Given this list of marker genes NUDT4, GSPT1, DSCC1, MPO, CEP76, TPM1 (NCBI Gene Id 7168), PALM2AKAP2, ITGB3BP, CCNB1, NUP85, NT5DC2, NUSAP1, MS4A3, RNASEH2A, CENPA, MRPS15, SPAG5, DLGAP5, CCNE1, MICAL2, DHFR, SUB1, CPA3, ARHGAP19, RAB31, RACGAP1, CSE1L, KIF2C, TUBB6, DLC1, PF4, PRDX4, BRCA1, ACTN1, CCNA2, ABCC4, KLHL7 (kelch like family member 7), CPOX, HBD, VRK1, HSPA14, CHEK1, FEN1, MCM10, AQP3, CCNE2, MCM4, IDH2, UBE2C, KIF18B, PROS1, TK1, TOP2A, RRM2, CDC7, FANCI (NCBI Gene Id 751608), CEP55, LEPR, STMN1, RRM1, SFXN1, PIEZO2, RHAG, SLC25A13, TRIP13, CENPU, RMDN1, TPSAB1, SAMM50, CCNB2, PRDX2, GGH, TST, ACOT7, PCLAF, RAD51, PDLIM1, AMMECR1, KIF15, SERPINB2, CCL2, OIP5, ABCD3, HMMR, LMNA, HBB (NCBI Gene Id 3043), TPX2, NUDT1, XIST, HBG1, LAT, CLC, LRRC59, UBE2S, CDC45 (cell division cycle 45), SHMT2, CST7, POLE2, PRKAR2B, PBK, TYMS, PPBP, RANBP1, SLC7A5, HDC, DNAJC12, ELP5, PRG2 (proteoglycan 2, pro eosinophil major basic protein), RPA3, FABP5, ITGA2B, KPNA2, NDC80, SYNCRIP, SNRPD1, AURKA, DUT (deoxyuridine triphosphatase), H2AX, KIF4A, CDKN3, CDK1, NEK2, ELOVL6, MCM5 (minichromosome maintenance complex component 5), NCAPG, RFC4, MELK, GINS2, STK39, ESPL1, ZNF593, SUCLA2, PMP22, SPC25, BUB1B (BUB1 mitotic checkpoint serine/threonine kinase B), NPM3, FBXO5, E2F8, APOBEC3B, CDC6, ATP5MC3, ECT2, LSM5, CENPF, MAD2L1, RFC3, CENPM, ASPM, BIRC5, CSTA, XK, MINPP1, RAD51AP1, HGF (hepatocyte growth factor), KIF20A, AURKB, EZH2, HAT1, MCM2 (minichromosome maintenance complex component 2), TTK, BUB1, MRPS28, GINS1, CLEC11A, PDSS1, EIF1AX (eukaryotic translation initiation factor 1A X-linked), RNASE2CP, RNASE2, ZWINT, SMC2, KLF1, CKS1B, SAC3D1, GMNN, CD36, CDC20, H1-2, PPIF, TFR2, KIF11, COTL1, SORD, HPGDS, SNRNP25, PRC1, here is a description of the gene set: Quiescent and dividing hemopoietic stem cells (HSC) display marked differences in their ability to move between the peripheral circulation and the bone marrow. Specifically, long-term engraftment potential predominantly resides in the quiescent HSC subfraction, and G-CSF mobilization results in the preferential accumulation of quiescent HSC in the periphery. In contrast, stem cells from chronic myeloid leukemia (CML) patients display a constitutive presence in the circulation. To understand the molecular basis for this, we have used microarray technology to analyze the transcriptional differences between dividing and quiescent, normal, and CML-derived CD34+ cells. Our data show a remarkable transcriptional similarity between normal and CML dividing cells, suggesting that the effects of BCR-ABL on the CD34+ cell transcriptome are more limited than previously thought. In addition, we show that quiescent CML cells are more similar to their dividing counterparts than quiescent normal cells are to theirs. We also show these transcriptional differences to be reflected in the altered proliferative activity of normal and CML CD34+ cells. Of the most interest is that the major class of genes that is more abundant in the quiescent cells compared with the dividing cells encodes members of the chemokine family. We propose a role for chemokines expressed by quiescent HSC in the orchestration of CD34+ cell mobilization. Disclosure of potential conflicts of interest is found at the end of this article. from publication Graham SM, Vass JK, Holyoake TL, Graham GJ (PMID 17717066) Human Gene Set: GRAHAM_CML_DIVIDING_VS_NORMAL_QUIESCENT_UP Genes up-regulated in quiescent CD34+ cells isolated from peripheral blood of normal donors compared to the dividing cells from CML (chronic myeloid leukemia) patients. species: Homo sapiens